Given this list of marker genes Gabarap, Becn2, Becn1, Map1lc3a, Gabarapl1, Map1lc3b, Gabarapl2, Atg5, Atg7, here is a description of the gene set: Any process that results in a change in state or activity of a cell (in terms of movement, secretion, enzyme production, gene expression, etc.) as a result of a stimulus reflecting the presence, absence, or concentration of inorganic nitrogen. Mouse Gene Set: GOBP_CELLULAR_RESPONSE_TO_NITROGEN_LEVELS species: Mus musculus